Given this list of marker genes MIR130A (NCBI Gene Id 406919), MIR145, MIR485, TPI1, GSK3A, APAF1, EXOSC3, HPRT1, CAPRIN1, CNP, MIRLET7C, ELOB, ARID5A, HK2 (hexokinase 2), GPI, GSPT2, NUDT17, SLIRP, MIR4286, TREX2, CNOT10, RNASEH1, ENTPD7, NPM1, SLFN13, ENTPD2, NORAD, ZCCHC8, TUT7, ARL2, MIR27A, MIR192, VIP, NEAT1, PGAM4, MTAP, PFKFB2, MLXIPL, RBM38, INTS10, TOB1, CNOT9, SMG7, MIR142, AGO1, PRKACA, ALDOA, YTHDF1, CALCR, RNASE3, SSB, HNRNPC, RBM7, DNASE1, MIRLET7B, EIF4ENIF1, TENT4B, MOV10, FOXL2, TRNT1, MIR181B1, MIR26B, EXOSC9, MIR655, MIR211, PIWIL2, VNN1, AXIN2, NUDT5, MIR106A, RBX1, NTHL1, RNASEL, METTL14, XRN2, PPARA, SCGB1A1, OGDHL (oxoglutarate dehydrogenase L), AMPD3, UPB1, TENT5D, CNOT1, CNOT6L, NUDT4, ZCCHC7, DNA2, PDE4D, PFKM, PRKAG1, CNOT7, CARHSP1, EDC3, PRKCD, SLC4A4, DBR1, GPD1, EXOSC2, YBX3, TENT4A, LSM5, MIR20B, CSDC2, MIR24-1, GTPBP2, MIR200B, MIR486-1, TRIM71, MIR214, INTS6, MRTO4 (NCBI Gene Id 94394), ZBTB20, RBM33, ZAR1, MIR223, MIR365A, VPS54 (NCBI Gene Id 51542), DNPH1, SLFN12, NRDE2, NANOS2, DPYD, RNASEH2A, PGK2, RBM24, SKIC3, CBFA2T3, PRTFDC1, MIR146A, GAPDH, YTHDF3, DUT, EIF3E, YBX1 (NCBI Gene Id 7806), FOXK1, MAGOH, TRIR, MIR625, FHIT, DIS3L, SERBP1, INTS4, UPF3B, FASTKD3, CIRBP, JMJD8, ROCK1, MIR96, MIR320A, DHX9, MIR501, KHSRP, LSM2, SAMHD1, MIR18A, IGF2BP2, PRKAA1, MIR181D, INTS15, RIDA, DNASE2B, NUDT8, DDX5, METTL3, TTC5, CNOT3, PRKCA, SKIC8, MIR885, MIR206, METTL16, MGAT1, C1QBP, SLC11A1, TRAF2, BOLL, SMG5, MIR564, DCTPP1, DCP1B, DNM3OS, TNRC6B, CNOT11, SECISBP2, NUDT16L1, MIR190B, LIPA, CNOT2, IGF2BP1, DCP2, RNH1, MIR20A, MIR663A, MIR103B1, ELOC, TREX1, PRR5L, SAMD4A, RNASE2, TRDMT1, MIR151A, PABPN1L (PABPN1 like, cytoplasmic), MTREX (NCBI Gene Id 23517), GRSF1, NCOR1, ZC3H14, RNASEH2B, MAPK14, MIR135B, RC3H1, INTS8, CDADC1, MIR193A, GALK1, MIR100, DFFA, DPYS, MIR302C, MIR137, RBM46, EXOSC5, MIR23A, PDE5A, LARP1, MIR337, POLR2G, PATL1, DIS3, ADPGK, LIN28B, SIRT6, MYD88, PFKP, MIR340, BCL2L13, ELAVL1, MIR98, FUS, NT5E (NCBI Gene Id 4907), DFFB, PNRC2, FOXK2, HNRNPAB, SLC2A6, FASTKD2, MIR708, VIM, MIR665 (NCBI Gene Id 100126315), APEX1, PFKFB1, TRAF3IP2 (TRAF3 interacting protein 2), INTS7, SRC, MIR19A, DDX49 (NCBI Gene Id 54701), ENO1, FBP1, NANOS1, ERN2, PABPC1, PUM1, ZFP36L1, PGM1, NUDT3, MIR608, PRXL2C (NCBI Gene Id 203335), PYM1, CNOT8, ARMC5, COL6A1, EXOSC7, HIF1A, DCPS, MLYCD, ETF1, NT5C1B, MIR191, TAF15, SIDT2, METTL1 (NCBI Gene Id 4234), PNRC1, FEN1, ENTPD1, MIR29B1, IREB2, ENPP3, EXOSC10, RBM10, CACNG7, MIR27B, STAT3, SMG8, ZSWIM8, THRAP3, MAPDA, ZHX2, MAGOHB, HNRNPD, FASTKD5, QKI, GIGYF2, MIR326, AKT1, ABCD1, PIWIL1, ATM, MAPKAPK2, SMUG1, DKC1, APOBEC1, LSM7, OAS2, OGG1, EIF6, LSM1, EP300, TESK1, INS, CNOT6, EXOSC8, VCP, FASTKD1, BPGM, UCP2, DAZL, ANGEL2, TBRG4, SMG6, NEIL1, NOCT, NT5C3B, MALAT1, PRKAG3, DNASE1L3 (NCBI Gene Id 1776), PAN3, ZC3H12A, WDR82, OGDH, MIR140, EXOSC1, ZC3H4 (NCBI Gene Id 23211), GTSF1, MIR9-1, DAZ2, CNOT4, ITPA, ALKBH5, SUCLA2, XIST, NT5C2, SETMAR (SET domain and mariner transposase fusion gene), HSPA1B, SUCLG2, NUDT10, PUM2, PGK1, APOBEC3G, CELF1, TNFRSF1B, SAMD4B, PGAM1, MIR203A, PRKAG2, ENTPD3, LARP1B, NCBP2, PNLDC1, ALDOC, ELAC2, TENT5A, FASTK, MIR195, PPP1R8, MIR329-1, NSUN4, PDE1A, MIR544A, NUDT4B, ANG, DEDD2, SUCLG1, INTS1 (NCBI Gene Id 392616), PIAS4, IKBKE, MIR491 (microRNA 491), OIP5-AS1, SKIC2, NUDT7, PDE9A, EXOG, MIRLET7A1, NBAS, ALDOB, MIR149, APP, MIR181A2, HTR2A, ENO3, ACOT7, EDC4, BAX, MIR520C, MIR519D, MIR373, AGO2, NUDT15, MIR130B, LSM14B, KAT2B (lysine acetyltransferase 2B), GDA, PCBP4, TENT5B, PKLR, MIR517A, SARM1, TNKS1BP1, TIRAP, TDG, MLST8, HOTTIP, NUDT16, UNG, MIR181C, PABPC4 (NCBI Gene Id 8761), SUPV3L1, FBLL1, ENTPD8, NBDY, CTIF, MIR212, PRKAA2, TARDBP, RBM47, NUDT1, CSDE1 (cold shock domain containing E1), DCP1A, GSPT1, PATL2, INTS2, MIR185, IGF1, MBD4, MTCH2, INTS11, DIS3L2, LARP4B, TNRC6C, MIR19B1, PDE10A, UPP1, DNASE1L2, A1CF, MIR204, DICER1, IER3, MIR1-1, ACTN3, MUS81, GIT1, DNASE2, MIR342, ZC3H18, INTS13, MIR497, ADA2, NUDT19, DCTD, LSM4, MIR93, ENPP1, ENPP4, YTHDF2, ZCCHC17, HSF1, ENTPD5, EIF4A3, UPP2, RNPS1, MLH1, ERN1, UPF2, DXO, PDE7B, PDE2A, DHTKD1, NEIL2, DERA, ENTPD4, TUT1, RNASE6, MIR133A1, SYNCRIP, PGAM2, PKM, GTPBP1, NUDT11, SENP1, SLC4A1, MTPAP, TENT2, NMNAT1, SMPDL3A, MIR30B, FLCN, TENT5C, PLEKHN1, FAM76B, DHX34, INTS5, SMG9, MIR483, AGO3, NT5M, PELO, HDAC4, RBM8A, FTO, PHAX, EXOSC4, MIR562, MTOR, LSM6, MIR495, DAZ1, XRN1, MIR210, HK3, MIR423, SMG1, IGF2BP3, ZFP36, NUDT13, EXOSC6, MIRLET7E, MIR128-1, DHX36, GAPDHS, RNASET2, NUDT9, FXR1, MIR125A, ZBTB7A, DAZ3, ENDOG, ENO4, P2RX7, MIR302A, FITM2, HSPA1A, PPP2R1A, RNASEH2C, FBH1, CPEB3 (cytoplasmic polyadenylation element binding protein 3, NCBI Gene Id 22849), MIR519A1, NUDT18, MIR200C, MIR424, MIR125B1, MIR543, POP1, ENO2, NCBP1, ACAT1, INTS3, LRPPRC, PFKFB3, PAIP1, INTS14, CIDEA, TIGAR, ZPR1, LIN28A, INSR, TUT4, PKP3, SND1, CECR2, DDIT4, APOBEC3C, PKP1, DNASE1L1, PDE4A, GDNF, ZFP36L2, NUPR1, ERI1, UCHL1, ISG20, HKDC1, MIR106B, TYMP, IFNG, MIR199B (NCBI Gene Id 406978), UPF3A, SRSF1, BTG2, MIR34B, FXR2, PDE4C, NT5C1A, RPTOR, NANOS3, HBS1L, OGT, PDE7A, PAN2, HNRNPU, PFKL (phosphofructokinase, liver type), CDA, ADA, INTS12, NICOL1, MEIOC, HK1, ZC3HAV1, AICDA, RC3H2, PDE12, UPF1, PPP2CA, ELAVL4, FMR1, PNPT1, NT5C, MEX3D (mex-3 RNA binding family member D), MFSD8 (major facilitator superfamily domain containing 8), TRIM63 (NCBI Gene Id 84676), REXO4, PDE8B, HINT1, DAZ4, PDE8A, GATA5, ROCK2, ZC3H12D (zinc finger CCCH-type containing 12D), TRAF5, AGO4, INTS9, HNRNPA0, PSEN1, DND1, PNP, SLFN14, XDH, E2F1, NSUN2, TNRC6A, PDE4B, CASC3, LDHA, NUDT12, NAF1, MIR517C, PARN (NCBI Gene Id 5073), GCK, FKRP (NCBI Gene Id 79147), ARNT, IL6, here is a description of the gene set: Human Gene Set: GOBP_NUCLEOBASE_CONTAINING_COMPOUND_CATABOLIC_PROCESS studied in species Homo sapiens The chemical reactions and pathways resulting in the breakdown of nucleobases, nucleosides, nucleotides and nucleic acids.